Given this list of marker genes Igf2r, Dnm2, Hip1r, Ap1g2, M6pr, Ap1m1, Ocrl, Cpd, Stx4a, Necap1, Picalm, Ap4s1, Arf1, Vamp2, Rab5c, Gak (NCBI Gene Id 231580), Tpd52l1, Pik3c2a, Snx9, Fth1, Snx2 (sorting nexin 2), Dtnbp1, Yipf6, Bloc1s1, Ap3s1, Vamp8, Clvs2, Dnase2a, Ap1s3, Ap1s1, Ap1b1, Bloc1s3, Dnajc6, Pum1, Chmp2a, Cltb, here is a description of the gene set: This event has been computationally inferred from an event that has been demonstrated in another species.<p>The inference is based on the homology mapping from PANTHER. Briefly, reactions for which all involved PhysicalEntities (in input, output and catalyst) have a mapped orthologue/paralogue (for complexes at least 75% of components must have a mapping) are inferred to the other species. electronically inferred by orthology from the curated human pathway Reactome Pathway: trans-Golgi Network Vesicle Budding part of: Membrane Trafficking studied in species Mus musculus